Given this list of marker genes Entpd7, Ddx41, Nectin2, Cyp2g1, Ephb4, Septin5, Spopl, Xylb, Cacfd1, Apba1, Sdccag8, Tpm2, Oas3, Nf1, Leng8, Sox13, Rab3d, Castor2, Zfp385a (zinc finger protein 385A), Pde4a, Elk1, Scamp4, Spib, 1700030J22Rik, Mlst8, Rreb1, Erf, Nrbp1, Gm14308, Tspan11, Ccdc97, Mtcl2, AI597479 (NCBI Gene Id 98404), Mrc2, Spock2, Nos1 (NCBI Gene Id 76730), Tcp11l1, Tmem164, Daam2, Cntn2, Cenpb (centromere protein B), Hlf, Smchd1, Zfp58, Cyth1, Arf5, Diras1, Arid1a, Pou2f2, Brinp2, Trim27, Ppard, Celf5, Eda, Iqsec3, Ppp1r9b, Lamc3, Sox4, Kif21b, Rnf216, 2900026A02Rik, Ngfr, Gnao1, Slco2b1, Zfp983, Trhde, Nmnat2, Fscn1, Rpgrip1l, Atxn7l3, Gpd1 (glycerol-3-phosphate dehydrogenase 1 (soluble)), Ptgdr2, Gmeb2, Tef, Rph3a, Tbc1d16, Cbl, Tnfsfm13, Nacc1, Ddb1, Wfdc5, Gm4724, Nfic, Ankmy2, Ctnnd1, Cry2, Bsn, Chdh, Pgs1, Gm2026, Gpx5, Smarcd2, Tspan2, Ccdc82, Gm12185, Capn8, Rbm28, Bak1, Tmem104, Erv3, Tob2, Vamp2, Cnot3, Prr14l, Elavl1, Gprin1, Cacna2d1, Ttyh3, Kdm5c, Elavl3, Mef2d, Camk1d, Pacsin1, Pfdn1, Ucn3, Clstn1, Mllt1, Tpbpa, Adap1, Bcl2l1, Shisa7, S1pr3, Cyfip2, Limk1, Myl9, Hip1, Smarcd1, Slc2a4, Kif5a, Ptpa, Map6d1, Igf2, Srrm4, Vat1, Tmem8b, Bach2, Gm14434, Fbxo41, Dnmt3a, Mical2, Tgif2lx1, Tmem63b, Myrf, Zcchc24, Mpp7, Atxn1, Gm14296 (NCBI Gene Id 76958), Dennd1a, Prdm16, Serpinc1, Gng7, Asic1, Hepacam (hepatocyte cell adhesion molecule), P2rx7, Scamp5, Zfp385b, Hspb7 (heat shock protein family, member 7 (cardiovascular)), Tnrc18, C1qtnf1, 2210418O10Rik, Angel1, Sox12, Sema5a, Rogdi, Rab35, Nfasc, Capn1, Kdm6b, Pip5k1c, Nova2, Nfam1, Gm14322, Crtc1, Vsx2, A4galt, C1qtnf6, Serpinf2, Adgrl1, Nxn, Zc3h18, Nbl1, Hsbp1l1, Sec62, Zfp703, Gm5938, Atp2a3, Tgif2lx2, Bean1, Sptb, Spry4, Gm14325, Kif2c (kinesin family member 2C), Nipal3, Zfp710 (zinc finger protein 710), Hs6st1, Parvb, Meis2, Fam78a, Shisa6 (NCBI Gene Id 380702), Spindoc, Cblb, Pou2f1 (NCBI Gene Id 18986), Taok3, Epha8, Slc6a8, Zfp593, Stat3, Tnfsf13, Celf3, Ctdsp1, Epb41l4b, Dok4, Nfix, Barhl1, Zfp827, Trim3, Nkd1, Dusp3, Hectd4, Klrg2, Mink1, Mmab, Twf2, Kcnj5, Rasl10b, Nek7, Herpud1, Kirrel3, Kcnc3, Dhdds, Ywhae, Nav1, Cacna1e, here is a description of the gene set: species: Mus musculus from publication Chen Y, Wang X (PMID 31504780) Mouse Gene Set: MIR_7075_5P Genes predicted to be targets of miRBase v22 microRNA mmu_miR_7075_5p in miRDB v6.0 with MirTarget v4 prediction scores > 80 (high confidence targets).